The following is a description of a gene set: studied in species Homo sapiens Reactome Pathway: Reversal of alkylation damage by DNA dioxygenases part of: DNA Damage Reversal DNA in cells is susceptible to different types of cytotoxic and mutagenic damage caused by alkylating agents. These genotoxic chemicals generate major lesions like 1-methyladenine, 3-methyladenine, 3-methylcytosine and O6-methylguanine in DNA. Cells have built in repair mechanisms against such toxic molecules. For example, 3-methyladeninie-DNA glycosylases excise some methylated bases while MGMT/hAGT protein transfers alkyl groups from others lesions onto cysteine residues. E.coli AlkB protein has a unique function wherein 1-methyladenine and 3-methylcytosine are demethylated by a combination of oxidative decarboxylation and hydroxylation activities. AlkB and its human orthologs, ALKBH2 (ABH2) and ALKBH3 (ABH3) belong to alpha-ketoglutarate deoxygenase family of enzymes that oxidize chemically inert compounds in the presence of alpha-ketoglutarate, oxygen and ferrous ions. As a byproduct of these chemical reactions, formaldehyde is released in the case of methylated lesions and acetaldehyde in the case 1-ethyladenine in DNA. CO2 and succinate are also released in an intermediate step not shown in the following illustration. Unlike other mechanisms which involve some kind of nuclease activities, this type of repair mechanism leaves the repaired bases intact by just removing the reactive alkyl groups that get bound to the bases thereby effecting accurate restoration of damaged DNA sequences., and this is the list of marker genes: ASCC2, ALKBH3, ASCC3, FTO, ALKBH2 (NCBI Gene Id 121642), ALKBH5, ASCC1